The following is a description of a gene set: species: Homo sapiens Human Gene Set: GOBP_REGULATION_OF_TYPE_2_MITOPHAGY Any process that modulates the frequency, rate or extent of type 2 mitophagy., and this is the list of marker genes: HTRA2, HDAC6, CDC37, VDAC1, PINK1, VPS13C, PRKN, GBA1, HK2, HUWE1, TOMM7, MUL1, ATP5IF1